The following is a description of a gene set: Mouse Gene Set: GOBP_POSITIVE_REGULATION_OF_KERATINOCYTE_DIFFERENTIATION Any process that activates or increases the frequency, rate or extent of keratinocyte differentiation. species: Mus musculus, and this is the list of marker genes: Prkch, Numa1, Macroh2a1, Med1, Etv4, Alox8, Macroh2a2, Ovol2, Cyp27b1, Notch1, Nme2, Ncoa3, Vdr, Pkp1, Foxc1